The following is a description of a gene set: species: Mus musculus Synthesis of PI Mouse Gene Set: REACTOME_SYNTHESIS_OF_PI, and this is the list of marker genes: Pitpnm2, Pitpnm1, Cds1, Pitpnm3, Cdipt